The following is a description of a gene set: Fragile, easily breakable hair, i.e., with reduced tensile strength. species: Homo sapiens Human Gene Set: HP_BRITTLE_HAIR Brittle hair, and this is the list of marker genes: SPINK5, KRT25, MAP2K1, ASL, RPS23, ST14 (ST14 transmembrane serine protease matriptase), OFD1, CDH3, SKIC3, KRT85, KRT81, KRT86, GNPTAB, SKIC2, SEC23A, GJA1, TCHH, DSG4, ZMPSTE24, SCUBE3 (NCBI Gene Id 222663), BCS1L, CBS, KREMEN1, KRT74, GJB6, PORCN, EDARADD, ERCC3, GTPBP2, TRNT1, CARS1, EDA, GTF2H5 (general transcription factor IIH subunit 5), RNF113A, SLC25A24, KRT83, ERCC2, NECTIN1, GTF2E2, KRAS, MPLKIP, BRAF, LPAR6, AARS1, ATP6V0A2, CDSN, MAP2K2, KRT71, LIPH, PRR12, ATP7A, ATAD3A, TARS1, PQBP1, MPV17 (mitochondrial inner membrane protein MPV17), NFIX